The following is a description of a gene set: Oligonucleotide microarrays were used to establish a profile for gene expression in wild-type airway epithelial cells after paramyxoviral infection. Analysis was performed on mRNA isolated from SeV-infected primary-culture mouse tracheal epithelial cells that were maintained under physiologic conditions (air-liquid interface). from publication Shornick LP, Wells AG, Zhang Y, Patel AC, Huang G, Takami K, Sosa M, Shukla NA, Agapov E, Holtzman MJ (PMID 18292557) studied in species Homo sapiens Human Gene Set: GSE10211_UV_INACT_SENDAI_VS_LIVE_SENDAI_VIRUS_TRACHEAL_EPITHELIAL_CELLS_UP Genes up-regulated in tracheal epithelial cells infected with UV inactivated versus intact Sendai virus., and this is the list of marker genes: FGD2, KLHL18, NANP, NCAPD3 (non-SMC condensin II complex subunit D3), MACF1, RFX6, RSU1, FAM110B, MTG2, C2orf42, GRAMD2B, TMEM186, SEMA4F, MTR, RNF39, ORAI2, MAP3K3, ACTRT2, CCDC152, ACYP1, TTC7B, DDX51, CD2AP (CD2 associated protein), POLR1A, MBOAT1, TBC1D1, JAKMIP1 (janus kinase and microtubule interacting protein 1), ANKRD44, CYP39A1, SPG7 (NCBI Gene Id 87549), LRRC42, EPM2AIP1 (NCBI Gene Id 9852), GIPC3, LTN1, EPAS1, ANKRD11, IL17RA, GRIN1, CLYBL, IKZF1, TAL1, SFRP1, SGMS1, BRF1, RAVER2, TINF2, DZIP1, SPINK8, ATP8A1, HEATR5A, GPR183, RBSN, BBS7, LRRC18, ACTR8, USP53, BRPF1, FLOT2, ANKRD36, DSE, S1PR1, HYKK, TXK, CARS1, DYRK1A, PABIR1, UGCG, GALNT2, NTRK3, POLE2, NLK, ANTXR1, TTYH3, PHF20L1 (PHD finger protein 20 like 1), AKT1S1, IL2, INO80, GPR132, ABTB2, IQGAP2, RAB28, HPCAL1, PXMP4, FOXP1, DAAM1, GPCPD1 (NCBI Gene Id 56261), VSX1, IDH2, BMP5, GTPBP1, LEF1 (lymphoid enhancer binding factor 1), PPIC, TSC1, LMBR1, SIDT1, PIAS2, PACRGL, FBLN1, CMKLR1, ZFYVE27, RAB11FIP4, PLA2G2F, GPR171, ARRB2, FXYD5, NMRK1, COX10, TBRG4, ANO4, POU6F1, XKRX, CENPJ, ARID3B, RIPOR2, KLHL5, MPND, RICTOR, SNAPC4 (NCBI Gene Id 80189), MAMDC2, IL7R, STX17, CFHR4, MIR17HG, EXD2, OVGP1 (NCBI Gene Id 8684), MRM3, EMB, PEPD, NELFCD, JAK1, PDE7A, CUZD1, LUC7L3, NUMB, TECPR2 (tectonin beta-propeller repeat containing 2), PCCB, SLC38A2, MTSS1, PDLIM1, RPS27, MIR450B, ENTPD6, FNTB, SHC4, ZNF318, GRAMD1A, PIM2, NEMP2, TRUB1, EIF4A2, SMAD4, SPOPL